The following is a description of a gene set: species: Homo sapiens Epithelial cell-cell contacts consist of three major adhesion systems: adherens junctions (AJs), tight junctions (TJs), and desmosomes. These adhesion systems differ in their function and composition. AJs play a critical role in initiating cell-cell contacts and promoting the maturation and maintenance of the contacts. TJs form physical barriers in various tissues and regulate paracellular transport of water, ions, and small water soluble molecules. Desmosomes mediate strong cell adhesion linking the intermediate filament cytoskeletons between cells and playing roles in wound repair, tissue morphogenesis, and cell signaling. Reactome Pathway: Cell-cell junction organization part of: Cell junction organization, and this is the list of marker genes: GANAB, CDH13 (NCBI Gene Id 1012), MOV10, SUZ12, H3C15, MIR9-3, CTBP1, CDH19, H2AC6, CLDN20, CLDN23, H4C1, H2BC11 (NCBI Gene Id 8970), CDH7, CLDN16, MAPK1, MTBP, CLDN22, SP1, CLDN4, MIR9-2, H2AC18, FOXJ2, PSMB6, PSMD12, STT3A, H2BC5, PKM, PSMB1, CDH10, CTSB, H3-3A, PSMD14, H2BC15, DNTTIP1, PSMD7, PSMB3, PSMA6, ZBTB33, JAK2, SDK1, H2BC3, H2BC4, NECTIN4 (nectin cell adhesion molecule 4), NECTIN3, IL6ST, RNF19B, OST4, ACTA1, PSMC6, ADAM19, PSMA1, ACTC1, CDH6, KDM1A, RPN2, DAD1, NECTIN1, CLDN14, CANX, PARD6G, SNAI1, ZEB2, CLDN18, CTSS, EPS15, TLE1, ACTB, PARD6B, CLDN12, KMT5A, PALS1, CLDN7, MYC, TRAF7, CLDN10, PCSK7, RPN1, RELA, H2BC1, H2BC26, CLDN1, SDK2, H2BC9, PSMD3, PSMC1, SNAI2, AFDN, HACE1, E, ZC3H12A, H2AC14, TMEM258, IL6, PSMD2, PSMB2, CTNNB1, CDH8, CDH9, TWIST2, MAPK3, AGO3, ANG, CLDN2, PSMC3, F11R, CDH15, FOXP2, H2AB1, CSNK2B, SPCS3, H2BC21, CDH11, BANP, PSMD8, TYK2, UBA52, XIAP, HDAC2, CLDN9, CDH1, PSMD6, ACTA2, PARD3, H2AC4, PSMB7, POMT1, IL6R, NFKB1, AGO2, ARHGEF4, ADRM1, TCF12, HEYL, CLDN19, ILF3, MIR451A, MCRIP1, ZEB1, CSNK2A2, AMOT, PSMC2, PSMC5, POMT2, FYN, WT1, HDAC1, PSMD13, SEC11A, VCL, PRKCSH, TNRC6C, PSMC4, CDH4, ANK3, H2AC20, PSMB4, FOXA2, CTBP2, UCA1, MIR10B, TIAM1, ADAM33, UBB, CLDN5, PSMA2, HOXC8, PSMA7, JUP, TCF3, ZMYM2, H2AC7, ZNF217, BHLHE22, MDM2, CLDN15, CDH17, CTNND1, CSNK2A3, NECTIN2, RBBP7, MOGS, PSMD1, DOCK1, PIP5K1C, CDH2, RBBP4, AGO1, STRAP, SIRT1, CTSL, PCSK6, ACTG2, FARP2, SMARCA4, ANGPTL4, TGIF2, FURIN, SEM1, TNRC6A, RAC1, FOXQ1, H2BC17, H2AX, MIR9-1, H2BC14, CBLL1, RPS27A, SOX10, ACTG1, PARD6A, H2BC12, CADM3, TFAP2A, CLDN3, ELMO1, TNRC6B (NCBI Gene Id 23112), OSTC, CLDN11, DDOST (dolichyl-diphosphooligosaccharide--protein glycosyltransferase non-catalytic subunit), MIR200C, EED, CDC42, MPHOSPH8, KLF4, CADM1, H2BC12L, RACK1, BIRC2, PSMD11, DNM2, CDH12, VAV2, CLDN6, SPCS2, CLDN17, H2BC13, PSMA4, CDH3, PSMA3, UBC, PSMA5, SEC11C, CSNK2A1, CADM2, JAK1, ARHGAP32, PRDM8 (NCBI Gene Id 56978), CLDN8, PVR, H3C1, SPCS1, CDH18, PSMB5, SRC, RB1, PATJ, H2AJ, CDH5, KLF9, EZH2, CTNNA1, MYCN, H2AZ2, ARID1A, TWIST1, STAT3, AGO4, CDH24 (cadherin 24), FOXF1, CRB3, PRKCI